The following is a description of a gene set: Mouse Gene Set: GOBP_NEGATIVE_REGULATION_OF_ERBB_SIGNALING_PATHWAY studied in species Mus musculus Any process that stops, prevents or reduces the frequency, rate or extent of ERBB signaling pathway., and this is the list of marker genes: Gprc5a, Cadm1, Rab7, Cbl, Itga1, Dusp3, Psen1, Zgpat, Egfr, Egf, Ptprf, Rnf126, Cblc, Rnf115, Snx5, Ptpn2 (protein tyrosine phosphatase, non-receptor type 2), Psen2, Chmp6, Nppa, Tsg101, Mvp, Spry2, Ptprj, Errfi1, Cblb, Grb2, Zfyve28, Lgmn, Vps25, Nup62, Socs5, Acp4, Tfap2a, Socs4, Dab2ip